Given this list of marker genes PPM1D, GMFB, DUSP5 (NCBI Gene Id 1847), CXCL1, SSBP1, XPC, MGST2, DUSP6, UBA2, HSPB2, ARF4, SERPINB2, YBX1, PPP2CB, TRIM23, RPA3, RPA1, SCG5, RPA2, ARF5, RAD23A, KHDRBS1, FUBP1, DUSP14, PPP6C, ZEB2 (NCBI Gene Id 9839), PRPSAP1, HMGB1, here is a description of the gene set: studied in species Homo sapiens Human Gene Set: MODULE_281 Phosphatase regulators.